Given this list of marker genes MAPK1, RAB1B, PLK1 (polo like kinase 1), CCNB1, GOLGA2, BLZF1, CDK1, GORASP1, RAB2A, CCNB2, GORASP2 (NCBI Gene Id 26003), USO1, RAB1A, MAPK3 (NCBI Gene Id 5595), here is a description of the gene set: species: Homo sapiens Reactome Pathway: Golgi Cisternae Pericentriolar Stack Reorganization part of: Mitotic Prophase The pericentriolar stacks of Golgi cisternae undergo extensive fragmentation and reorganization in mitosis.<br> <br>In mammalian cells, Golgi apparatus consists of stacked cisternae that are connected by tubules to form a ribbon-like structure in the perinuclear region, in vicinity of the centrosome. Reorganization of the Golgi apparatus during cell division allows both daughter cells to inherit this organelle, and may play additional roles in the organization of the mitotic spindle. <br> <br>First changes in the structure of the Golgi apparatus likely start in G2 and are subtle, involving unlinking of the Golgi ribbon into separate stacks. These changes are required for the entry of mammalian cells into mitosis. This initial unlinking of the Golgi ribbon depends on GRASP proteins and on CTBP1 (BARS) protein, which induces the cleavage of the tubular membranes connecting the stacks (Hidalgo Carcedo et al. 2004, Colanzi et al. 2007), but the exact mechanism is not known. Activation of MEK1/2 also contributes to unlinking of the Golgi ribbon in G2. <br> <br>From prophase to metaphase, Golgi cisternae undergo extensive fragmentation that is a consequence of unstacking of Golgi cisternae and cessation of transport through Golgi. At least three mitotic kinases, CDK1, PLK1 and MEK1, regulate these changes. CDK1 in complex with cyclin B phosphorylates GOLGA2 (GM130) and GORASP1 (GRASP65), constituents of a cis-Golgi membrane complex. Phosphorylation of GOLGA2 prevents binding of USO1 (p115), a protein localizing to the membrane of ER (endoplasmic reticulum) to Golgi transport vesicles and cis-Golgi, thereby impairing fusion of these vesicles with cis-Golgi cisternae and stopping ER to Golgi transport. Phosphorylation of GORASP1 by CDK1 enables further phosphorylation of GORASP1 by PLK1. Phosphorylation of GORASP1 by CDK1 and PLK1 impairs stacking of Golgi cisternae by interfering with formation of GORASP1 trans-oligomers that would normally link the Golgi cisternae together. <br><br> In the median Golgi, GORASP2 (GRASP55), a protein that forms a complex with BLFZ1 (Golgin-45) and RAB2A GTPase and contributes to cisternae stacking and Golgi trafficking, is also phosphorylated in mitosis. Phosphorylation of GORASP2 by MEK1/2-activated MAPK1 (ERK2) and/or MAPK3-3 (ERK1b in human, Erk1c in rat) contributes to Golgi unlinking in G2 and fragmentation of Golgi cisternae in mitotic prophase.